The following is a description of a gene set: species: Homo sapiens Modulation by Mtb of host immune system Human Gene Set: REACTOME_MODULATION_BY_MTB_OF_HOST_IMMUNE_SYSTEM, and this is the list of marker genes: B2M, RPS27A, TLR2, UBC, UBB, UBA52, MRC1